Given this list of marker genes C4B, PLA2G7, PDGFRA, COL3A1, STAT1, IRF7, SNAI1, PDGFRB, HTRA1, CXCL6, VLDLR, ISG15, COL6A1 (collagen type VI alpha 1 chain), CCL2, CDH2, SERPINH1, PTGS1, PHGDH, SLPI, UPP1 (uridine phosphorylase 1), CDH15, MMP13, TNC, PROCR, PMP22, ASNS, IFIT3, ACKR3, IL11, ADA, MTHFD2, MMP12, S100A8, PTPN22, CSN3, DDR2, BCL3, DAB2 (NCBI Gene Id 1601), IFIT1B, CYP1B1, CTSZ, PCOLCE, RRAS, LAMB1, SDC2, GAS1, RNASET2, TNXB, INHBA, SRM, GALK1, IFITM3, CD68, VIM, CFH, ADSS1 (NCBI Gene Id 122622), COL6A2, MMP2, CCK, PPIC, FMO1, HIF1A, SDC1, SPARC, SLC3A2, B2M, DCN, here is a description of the gene set: species: Mus musculus Genes up-regulated during epithelial to mesenchymal transition (EMT) induced by TGFB1 in the EpH4 cells (mammary epithelium cell line transformed by HRAS). Epithelial-to-mesenchymal transition (EMT), a switch of polarized epithelial cells to a migratory, fibroblastoid phenotype, is increasingly considered as an important event during malignant tumor progression and metastasis. To identify molecular players involved in EMT and metastasis, we performed expression profiling of a set of combined in vitro/in vivo cellular models, based on clonal, fully polarized mammary epithelial cells. Seven closely related cell pairs were used, which were modified by defined oncogenes and/or external factors and showed specific aspects of epithelial plasticity relevant to cell migration, local invasion and metastasis. Since mRNA levels do not necessarily reflect protein levels in cells, we used an improved expression profiling method based on polysome-bound RNA, suitable to analyse global gene expression on Affymetrix chips. A substantial fraction of all regulated genes was found to be exclusively controlled at the translational level. Furthermore, profiling of the above multiple cell pairs allowed one to identify small numbers of genes by cluster analysis, specifically correlating gene expression with EMT, metastasis, scattering and/or oncogene function. A small set of genes specifically regulated during EMT was identified, including key regulators and signaling pathways involved in cell proliferation, epithelial polarity, survival and trans-differentiation to mesenchymal-like cells with invasive behavior. from publication Jechlinger M, Grunert S, Tamir IH, Janda E, Lüdemann S, Waerner T, Seither P, Weith A, Beug H, Kraut N (PMID 14562044) Human Gene Set: JECHLINGER_EPITHELIAL_TO_MESENCHYMAL_TRANSITION_UP